Given this list of marker genes RN7SL461P, ZFP64P1, CNIH1, ATG14, LINC02284, ATL1, TMX1, ENSG00000297446, KTN1-AS1, RPSAP13, CGRRF1, LINC02319, NID2, DDHD1, LINC00519, SAMD4A, RNU6-301P, BMP4, EXOC5, GMFB, CHMP4BP1, RPL36AP1, CDKL1, ENSG00000259868, HMGN1P1, LINC00520, ENSG00000304907 (novel transcript), NIN, PTGDR, MAP4K5, ENSG00000258803, RNU6-1291P (NCBI Gene Id 106481588), TMEM260, COX5AP2, MIR5580, ATP5F1CP1 (ATP synthase F1 subunit gamma pseudogene 1), DDHD1-DT, TBPL2, FDPSP3, RNU6ATAC9P, PELI2, RPL21P6, RPL3P3, PSMC6, MIR4308, ENSG00000259039, RPL7AP4 (ribosomal protein L7a pseudogene 4), OTX2, PTGER2, CDKN3, LGALS3, FRMD6-AS2, STYX, TXNDC16, MAPK1IP1L, OR7E159P, SOCS4, WDHD1, FERMT2, ENSG00000252945, GCH1, ENSG00000258843, SETP2, ABHD12B, NAA30, COX5AP1, PYGL, ERO1A, FBXO34-AS1, RPL13AP3, DLGAP5, LINC03059, FBXO34, KTN1, OR7E106P, RNA5SP385, GPR137C, OR7E105P, LINC00640, TRIM9, LINC02331, ENSG00000258928 (NCBI Gene Id 102723604), SAMD4A-AS1, SAV1, ABI1P1, ENSG00000287156, RN7SL452P, GNPNAT1, SNORA70, RPS3AP46, CCDC198, ENSG00000293989, RTRAF, SNRPGP1, AP5M1, OTX2-AS1, GNG2, RNU6-1204P, FRMD6, here is a description of the gene set: species: Homo sapiens Human Gene Set: chr14q22